Given this list of marker genes DYRK1A, APC2, CAPN3, ERGIC1, TPM2, ATP5F1D, PSAT1, DAG1, SELENON, RYR1, SYT2, SVIL, DDR2, SPG11, COL6A3, RPL10, PNPT1 (NCBI Gene Id 87178), SPTBN4, MMP2, NFATC2, TNNT1 (NCBI Gene Id 7138), FKBP10, NSD1, HNRNPA2B1, VARS1, ESCO2, COG8, FIG4, ADAMTS15, SLC1A4, LGI4, FLNA, TPM3, HACD1, COL25A1, PI4KA, KLHL9, COL6A2, C19orf12, MAP3K20, MYL2, SGCA, SCYL2, C18orf32, NT5C2, ERLIN2, TOR1AIP1, RTTN, ANO5, REEP1, ADSS1 (adenylosuccinate synthase 1), NEB, SLC4A10, ITGA7, ACTA1, COL6A1, DPM1, ALAD, UBA1, ORAI1, COL12A1, here is a description of the gene set: studied in species Homo sapiens Human Gene Set: HP_ANKLE_CONTRACTURE Ankle contracture